Given this list of marker genes LIF, IL11RA, LIFR, CNTFR, CTF1, IL11, JAK1, IL31RA, OSMR, CLCF1, IL6ST, IL31, TYK2, CNTF, JAK2 (Janus kinase 2), OSM, CRLF1, here is a description of the gene set: IL-6-type cytokine receptor ligand interactions species: Homo sapiens Human Gene Set: REACTOME_IL_6_TYPE_CYTOKINE_RECEPTOR_LIGAND_INTERACTIONS